The following is a description of a gene set: from publication Zhang L, Long W, Xu W, Chen X, Zhao X, Wu B (PMID 35669188) Mouse Gene Set: ZHANG_UTERUS_C0_SECRETORY_STROMAL3_NPPC_HIGH_CELL Table S2: Representative genes of each cell cluster studied in species Mus musculus, and this is the list of marker genes: Gm6807, Gm14303, Mmp19, Rps27rt, Nme2, Adam12, Zfand5, Adprh, Col4a1, Cd164, Ilk, Gm4149, Dnajb4, Serp1, Tubb6, Rplp0 (NCBI Gene Id 64336), Fstl1, Tbrg1, Klf9, Sec13, Sap18, Eef1a1, Col4a2, Tmt1a, Sdc1, Ubb, Zxdc, Gm10250, Ngfr, Serf2, Rps15a-ps7, Capn2, Gm11478, Rpl9-ps6, Vim, Rasd1, mt-Nd3, Eif4ebp1, Maged2, Myl12a, Sparc, Gja1, Rpl31-ps8, Dstn, Gm12918, Col6a4, Bst2, Rpl36a-ps2, Rpl3-ps1, Adamts2, Tpt1-ps3, Rcn3, Gm7600, Anxa3, Ftl1-ps1, Tmem100, Hspa5, Oaf, Cald1, Rpn1, Surf4, Aqp1, Gm10288, Ppib, Tubb2a, Ubb-ps, Plod1, Myh10, Ppp3ca (protein phosphatase 3, catalytic subunit, alpha isoform), Cavin1, Ppp1r15a, Rps27a-ps3 (ribosomal protein S27A, pseudogene 3), P2ry14, Gm10736 (predicted gene 10736), Eef1g, Laptm4a, Copz2, Tmed2, A2m, Gm10269, Pdia6, Copb2, Ppic, Des, Rab1a, Pnrc1 (proline-rich nuclear receptor coactivator 1), Slc16a2, Ramp2, Rps23-ps1, Ahnak, Itga5, Rpl37rt, Copa, Gnl3, Htra1, Ggt5 (gamma-glutamyltransferase 5), Igfbp6, Msrb2, Gm10275, Gm10132, Vkorc1, Serpine1, Rab7b, Gm9843, Gm7536, Sec22b, Rpl6l, Trabd2b, Fermt2, Sdc4, Nucb1, Gng12, Mxra8, Jund, Ccl11, Actg1, Col6a2, Rps3a2, Errfi1, Ccnl1, Rpl7-ps9 (NCBI Gene Id 636008), Phlda1, Gpx8, Lox (lysyl oxidase), Ssr3, Rhoj, Eln, Cyb5a, Pgr (progesterone receptor), Csrnp1, Map1lc3a, Fos, Lamb1 (NCBI Gene Id 97822), Cav1, Spon1, Crispld2, Cd34, Lrp1, Gas6 (NCBI Gene Id 14456), Rpl4, Ewsr1, Umps, Sec61a1, Fbln2, Sec31a, Twist2, Meg3, Srm, Cnn3, Ehd2, Rpl36-ps2, Rps26-ps1, Col1a1, Hnrnpf, Scube1, Kdelr3, Qpct, Gm5586, Itgb5, Gapdh, Calu, Ube2g2, Klf6, Sar1a, Rps15a-ps6, Aldh7a1, Wnt5a, Ehd1, Gm13588, Rps19-ps6, Tpm4, Gm14165 (NCBI Gene Id 630986), C1s1, Thbs1, Ugp2, 2310022B05Rik, Stt3a, Col6a3, Gm3788, Hsph1, Tnfaip3, Raly, Socs2, Sec61b (NCBI Gene Id 66212), Myc, Mfge8, C1ra, Gadd45g (growth arrest and DNA-damage-inducible 45 gamma), Sdk1, Pim3, Rdx (NCBI Gene Id 19684), Uba52rt, Fbxo32, Nfkbia, Axl, Tceal8, Anxa6, Serpinf1, Col6a1, Mmp23, Dusp1, Ssr4, Ctsh, Hdlbp, Sptssa, Gm3511, Tpm2, Serpinb6a, Trib1, Col15a1, Vapa, Myadm, Pofut2, Col5a1, Rps25-ps1, Inhbb, Rps6-ps4, Anapc5, Wdr89, Gm12174, Plpp3, Anxa5, Gm10076, Mfap5, Klf4, Copg1, Tppp3, Ltbp4, Rpl14-ps1, Hk2 (hexokinase 2), Cebpd, Steap3, Cd81, Palld, Smoc2, Jun, Rpl34-ps1, Sec61g (NCBI Gene Id 20335), Gm5905, Ssr1, Gm10177, Fkbp7, Gm9794, Rps6, Gm6863, Rpl10a, Ramp3, Ccl7, Sphk1, Rcn1, Ckb, Eif4a2, Rpl10a-ps1, Btg1, Eif1a (NCBI Gene Id 98102), Fkbp9, Akr1c14, Herpud1, Mir703, Pink1, Cavin3, Hspb8, Pim1 (NCBI Gene Id 18712), Gm8730, Wipi1, Tnfaip6, Man1a (mannosidase 1, alpha), Fosb, Rpl35rt, Hsd11b2, Gm13436, Maged1, Yipf5 (Yip1 domain family, member 5), Ckap4, Adm, Oxtr, Plod2, Igsf10, Ccl2, Cd248, Eif4e, Lmna, Btg2, Angptl4, Rpl19-ps11, Col1a2, Ier2, Tuba1a, Nppc, Myl6, Rpl28-ps1, Pdia3, Aldh1a2, Tmem258, Fbn1, Gm12481, Tcf4, Gm4366, Serpinh1, Ccn1, Arl4c, Rps7-ps3, Scd2, Gm8292, Maf, Ftl1, Loxl2, Gm9385, Ddost, Gm15427, Atp8a1, Rpl18-ps1, Cstb, Dnajb1, Arl1, Wls, Cd63-ps, Rps18-ps5, Il17ra, Ubc, Thy1, Tmem119, Morf4l2, Uba52, Rpl15, Ogn, Zfp36l1, Col5a2, Gm7808, Gm15772, Aldh1a1, Dio2, Idh1, Selenos, Fn1, Ost4, Prkar1a, Tmem109, Gm6204, Swi5, Sqstm1, Ddit4l, Gm15421, Txndc5, P4hb, Tmed3, Anxa1, Rpl10-ps3, Igf1, Rpl35, Lrig1, S100a16, Loxl1, Lgals1, Gm5526, Tnfrsf12a, Bag3, Dcn, Col3a1, Emb, Ebf1, Cryab, Sec24d, Rps10-ps2, Egr1, S100a6, Dap, Gm14586, Cxcl10, Gm10073, Gm5805, Anxa2, Emp1, Ackr3, Pnp, Sgk1 (serum/glucocorticoid regulated kinase 1), Slc25a39, Ifrd1, Prss23, Xbp1, Cd320, Gem, Gm8797, Plk2, Bhlhe40 (NCBI Gene Id 20893), Gm6136 (predicted pseudogene 6136), Arf4, S100a10, Spon2, Gsn, Kdelr2, Gstp1, Cdh11, Pgrmc1, Il6st, Bzw1, Col18a1, Rps13-ps2, Gm5835